The following is a description of a gene set: Mouse Gene Set: REACTOME_SYNTHESIS_SECRETION_AND_DEACYLATION_OF_GHRELIN species: Mus musculus Synthesis, secretion, and deacylation of Ghrelin, and this is the list of marker genes: Gcg, Ghrl, Pcsk1, Lep, Igf1, Spcs3, Sec11a, Sec11c, Ins1, Mboat4, Spcs1, Gh, Spcs2, Pla2g7, Bche